Given this list of marker genes KPNA2, AOC1, HSPD1, HSPE1 (heat shock protein family E (Hsp10) member 1), DNAJA1, PDIA6, VBP1, ERP29, ATF6, TOMM34, CCT6A, BAG3, PDIA5, LRPAP1, SSR2, DNAJC7, CCT4, TNPO1, PPIC, KDELR2, SSR1, FKBP1A, KDELR1, KPNB1, HSPA8, here is a description of the gene set: species: Homo sapiens Genes in the cancer module 155. Human Gene Set: MODULE_155